The following is a description of a gene set: A small/hypoplastic or absent/aplastic radius. Human Gene Set: HP_APLASIA_HYPOPLASIA_OF_THE_RADIUS studied in species Homo sapiens Aplasia/Hypoplasia of the radius, and this is the list of marker genes: EIF4A3, FGFR3, FANCM, FANCB, LMBR1, PLXND1, LRP4, NPR2, DVL1, CCNQ, NIPBL (NIPBL cohesin loading factor), MACROH2A1, FANCA, SLX4, XRCC2, APC, MMP13, IHH, PRKAR1A, COL2A1, CHD7, FGFR2, RFWD3, ERCC4, IFT81, MMP9, FGFR1, TRIO, RAD51C, FANCI, TNNI2, PDE4D (NCBI Gene Id 654081), DHODH, FANCF, FANCC, BRIP1 (NCBI Gene Id 83991), ROR2, REV3L, RECQL4, FLNB, GLI3, PITX1, NALCN, TPM2, RPL26, SALL4, PALB2, WNT7A, SHOX, FANCD2, FANCG, FANCL, RPS19, RAD51, ATR, DHCR7, TGFB1, UBE2T, AFF4, SF3B4, TNNT3, BRCA1, RBM8A, TBX3, MAD2L2, FKBP10, TRIP11, MYH3, RIPK4, MAFB, TBX5, ESCO2, DONSON, GDF5, SHH, CHN1, FANCE, BRCA2, ALG12, FGF10, RBM10, HOXD13, ZIC3